The following is a description of a gene set: Human Gene Set: LFA1_Q6 studied in species Homo sapiens Genes having at least one occurrence of the motif GGGSTCWR in the regions spanning 4 kb centered on their transcription starting sites. This matches the ITGAL transcription factor binding site V$LFA1_Q6 (v7.4 TRANSFAC)., and this is the list of marker genes: TUBA4A, LZTS2, EXD1, TBR1, LMOD3, FLI1, NCDN, BAHD1, PRSS36, SMAD3, PRDM10, TMEM88, ARID1A, ARAP3, SP7, RASGRP2, ISCA2, FLT1, SALL1, PPP1R16A, CRMP1, CCDC177, BACE1, PYGO2, PPY, CLUH, RBPJ, SLC7A10, CRNN, VSX2, MSX1, CEND1, MYBPH, ZBTB25, DDX17, OLFML2A, ROM1, NFKBIA, CPNE9, ELP5, PAK1IP1, PAX7, NEUROG1, DCTN1, NEURL1, GSK3B, SLC2A4, ETV1, RFX4, BRPF1, UBL3, KLK9, OTOP2, PRRX1, YPEL4, SEMA6A, RABGGTA, RASL12, CCN2, NACA, GNAO1, GAD1, SH3BP1, DHH, ARL6IP6, M6PR, RAB31, RBBP6, FES, HARS2, ZNF385A, VASP, PITPNA, CREB3L2, PRSS50, BAX, PCBP2, TMEM256, RAB5C, HES1, UPF2, GPR3 (G protein-coupled receptor 3), LIN28A, MGAT4C (NCBI Gene Id 25834), TMEM132E, CIMIP4, TTC9C, TUBA1A, ZFP36, ARL4D, CXCR4, PNOC, S100A5, ZNF513, CLTC, SIX4, TMEM190, ZMYND8, CASQ2, TAOK2, PLA2G10, PDYN, KLHDC7A (NCBI Gene Id 127707), MRPL40, NAA38, ADM, NKX2-1, PDZD9, XYLT1, POU4F1, COX7A2L, GBA2, MYOG, SLC25A29, RBM12, CNTNAP5, HOXC6, C11orf87, DMPK, USH1G, RAB1B, POLD4 (NCBI Gene Id 57804), DUOXA2, RHO, EPO, SLC26A9, ZNF800, ASXL1, MNT, NDUFS2, PDLIM7, TBC1D22A, ZNF524, CIC, TUBA4B, MAZ, IL1F10, HEBP1, OGA, SPEG, TMEM259, CAVIN1, CAV1, GPR4, GSS (glutathione synthetase), BCL6, NGF, DLGAP4, INCA1, HOXC10, SESN3, S1PR1, DPF2, PHF23, CAMKV, GABRG2, NR5A2, NPTXR, ADAMTS4, CKB, SMARCD2, CACNA1G, JAKMIP3, PDRG1, KIF1C, BCL11B, OSR1, CHP1, LAG3, LCAT (lecithin-cholesterol acyltransferase), KLK13, CPNE1, CCDC148, ZFPM1, NDUFA4L2, KCNQ4, AKT3, CCNL1, PHF12, JPH4, CLIC5, GABARAP (GABA type A receptor-associated protein), SCUBE3, NRGN, CEBPB, FKBP2, STOML2, MOV10, ANXA4, NPC2, TRIP10, EFNA3, PPM1J, PSD, NR4A1, IFRD2, PALM, NXF1, MED13, LRP8, CACNB1, CELF3 (CUGBP Elav-like family member 3), NYX, CNKSR2, CYB5D1 (NCBI Gene Id 124637), GRIN2A, PLEC, HIRA, TMEM131L, NPAS3, EMILIN1, UQCRC1, MARCHF6, ARHGEF15, SOX5, WNT4 (Wnt family member 4), BNC2, NFAT5, HNRNPR, TPCN1, RAB4B, BOC, PLA2G4D, TCF7, KCNAB1, ELF4, NIPBL, MYPN, TAL1, SYVN1, DLX1, FXYD3, RHOG, TSSK4, IQCD, DTD2, DUOX2, FIZ1, SLC13A5, IGSF21, IMMT, EPHB2, NKX2-3, NSG2, EML3 (EMAP like 3), ACVR1C, MCRS1, CNN2, ASIC2, OBSCN, ARID4A